Given this list of marker genes MCFD2, PLAU, TMED7, ZMYND8, POLR1F, B3GALNT1, TTC21B, SUGP2, MBTD1, HECTD3, RAB12, PHYHIPL, CCL5, ZFAND3 (zinc finger AN1-type containing 3), SLC8A1, PLEK, SYNGR3, MINDY2, HDAC6, FAM53B, MEF2A, PPM1E, CCDC66, XPO1, UBA2, PPIE (peptidylprolyl isomerase E), GCA, GJC1, ZNF521, TBC1D20, ZNF570, RAB22A, SCD, UGT2A3, LAMTOR3, SMARCA1, AMD1, PDZD8, LIX1 (limb and CNS expressed 1), TMEM267, here is a description of the gene set: from publication Chen Y, Wang X (PMID 31504780) Genes predicted to be targets of miRBase v22 microRNA hsa-miR-645 in miRDB v6.0 with MirTarget v4 prediction scores > 80 (high confidence targets). studied in species Homo sapiens Human Gene Set: MIR645